Given this list of marker genes Dact2, Dmrt1, Dand5, Lefty1, Dact1, here is a description of the gene set: Any process that modulates the frequency, rate or extent of nodal signaling pathway. Mouse Gene Set: GOBP_REGULATION_OF_NODAL_SIGNALING_PATHWAY species: Mus musculus